Given this list of marker genes Satb1, Cwc25, Cd84, Spesp1, Afdn, Ric1, Ulk2, Sarm1, Cyp2c50, Adgrl1, Atf6, Galnt7, Atp4a, Atad1, Rdh13 (NCBI Gene Id 71482), Semg1, Pramel12, Cyp1a1, Dlg3, Mettl8, Nsun4, Fli1, Mllt6, Fndc3a, Arhgap11a, Afg2a, Otud7b, Wscd2, Rnd3, Tmem200a, here is a description of the gene set: Mouse Gene Set: MIR_6920_3P studied in species Mus musculus from publication Chen Y, Wang X (PMID 31504780) Genes predicted to be targets of miRBase v22 microRNA mmu_miR_6920_3p in miRDB v6.0 with MirTarget v4 prediction scores > 80 (high confidence targets).